Given this list of marker genes NR3C1, GCK, TRIM63, FOXO1, NPY, HDAC1, ABCA6, SOD2, FOXO3, RETN, SMAD2 (SMAD family member 2), PLXNA4, PPARGC1A (NCBI Gene Id 10891), INS, POMC, PCK1, G6PC1, AGRP, FOXO4, SIN3A, ATXN3, SREBF1, SIRT3, FBXO32, FOXO6, CAT, SMAD4, IGFBP1, HDAC2, SMAD3, here is a description of the gene set: Human Gene Set: REACTOME_FOXO_MEDIATED_TRANSCRIPTION_OF_OXIDATIVE_STRESS_METABOLIC_AND_NEURONAL_GENES studied in species Homo sapiens FOXO-mediated transcription of oxidative stress, metabolic and neuronal genes